The following is a description of a gene set: Genes up-regulated in comparison of macrophages cultured with M-CSF versus macrophages cultured with M-CSF and IFNG. Gene expression analysis of freshly isolated CD14+ human monocytes and monocytes cultured in the presence or absence of interferon (IFN) -gamma for 24 h and then stimulated with Pam3Cys, a Toll-like receptor (TLR) 2 ligand, for 6 h. Results provide insight into mechanisms by which IFN-gamma reprograms early macrophage differentiation and subsequent response to TLR ligands. studied in species Homo sapiens Human Gene Set: GSE11864_CSF1_VS_CSF1_IFNG_IN_MAC_UP from publication Hu X, Chung AY, Wu I, Foldi J, Chen J, Ji JD, Tateya T, Kang YJ, Han J, Gessler M, Kageyama R, Ivashkiv LB (PMID 18976936), and this is the list of marker genes: FIG4, SLC12A6, SPIRE1, ANKZF1, CALHM2, RARRES1, ZMYM2, RPS6KA2, MBP, MAP1LC3C, ZMYND8, SPATA7, NISCH, LINC00921, SPTBN1, ITGAE, LINC00900, ZNF185, LYPD1, RIN2, CCDC18-AS1, RPRD2, HDAC5, SLC19A2 (NCBI Gene Id 7826), TMEM59, MATK, TMCC3, COL10A1, DHRS9, VPS8 (NCBI Gene Id 23355), IFT52, RSRC1, ARHGAP9, SH3YL1, CBY1, ZBED5-AS1, COBLL1 (NCBI Gene Id 22837), OIP5-AS1, ZNF395, SNX24, MERTK, ABCC4, PROX1-AS1, SIAH1, TMEM218, NUDT16L1, GGA2, ZNRF1, MGC16275, USP6 (NCBI Gene Id 9109), CELF5, PARL, SLC6A6, CXCL3, VAPA, TNFRSF8, LINC00636, TREM2, PTOV1, CCDC93, PHF10, PDE4A, VPS13A, ID3, ZNF641, PPM1H, CERS2, WDR35, SEC62, LZTFL1, NDRG1, MORF4L1, C1orf43, IFNGR1, ULK2, TMEM50B, EPHB2, TSHZ1, BNC2, AP1B1, ARMCX1, PARP2, REPS2, NUP214, CELF6, NME4, TBC1D8, CST6, CEP95, BEX3, SFR1 (SWI5 dependent homologous recombination repair protein 1), RNASE4, GPR34 (G protein-coupled receptor 34), ZCWPW2, GALNT11, GPR82 (NCBI Gene Id 27197), ATP6V1D (ATPase H+ transporting V1 subunit D, NCBI Gene Id 51382), CLEC11A, EIF1AX, GSDME, RAE1, IER5L, LMO2, PTGFRN, EMC3, WWP1, APMAP, MTA3, DUSP22, NFE2L2, DEPTOR, SWAP70, ERGIC3, TNRC6B, HP1BP3, SMARCE1, ITGB8, TNS1 (tensin 1), ZNF24, VMO1, IFT122, NME3, SLC26A4-AS1, CREM, SLC43A1, ENSG00000272447, GEM (NCBI Gene Id 2669), ZBTB40, KIF3C, C3AR1, PEAK1, RAB33A, NRXN2, UBL3, MIF4GD, MEPCE, TSPAN13, POMT1, TMEM167B, HFE, CD109, CNPY4, FARP1, SDF2, MED12, CPNE2, ZNF248, MCOLN1, RBP1, ATP2B1-AS1, LMBRD1, IGBP1, NQO2, TESK2, H2BC8, TFRC (transferrin receptor), TMEM234, KDM5D, BCHE, SRRM2, CREB1, ZNF274, CCNDBP1, IGF1R, ADHFE1, FAM234A, ZNF230, RHBDD2, CHD4, DNAAF11, VWA5A, STAB1, C2orf76, RNF145, LINC00910 (long intergenic non-protein coding RNA 910), IQCH-AS1, SLC7A8, LINC02223, SAMTOR, AP2A2, HNRNPH1, MARCKS, POR, CD247, HGF, DLGAP1-AS2, ID1, BRI3BP, SPEN-AS1, CEPT1, MB21D2, MIR663AHG, SLCO2B1, RPL41, AHNAK, RAB3D, ZHX2